The following is a description of a gene set: studied in species Homo sapiens Human Gene Set: MIR4477B from publication Chen Y, Wang X (PMID 31504780) Genes predicted to be targets of miRBase v22 microRNA hsa-miR-4477b in miRDB v6.0 with MirTarget v4 prediction scores > 80 (high confidence targets)., and this is the list of marker genes: CHCHD7, NAA30, ATP11A, MICAL3, MGAT4A, NEXN, DCP1A, NANP, STEAP2, CCNJ, HIPK3, FLRT3, SPRED1, MORC1, PHF6, WTAP, ZNF124, DYNLRB1, STARD5, MOB1B, TBL1XR1, SPOPL (speckle type BTB/POZ protein like), TRIM2, RNASE11, NID1, DGKH, BMP2, THBS1, PABPC1, PWP1, ZER1, TIPRL, SCN1A, KCTD7, AMZ1, PLAU, PDCD10, SREK1, CLOCK, CEP112, HEXIM1, AKAP8, MAGI3, EPM2AIP1, MED13, MON2, C14orf39, CDC73, UTP25, TSPYL1, DAZL, TMEM218, SPIN1 (NCBI Gene Id 95616), FGD4, CETN1 (NCBI Gene Id 1068), NCOR1, CRYL1, LSMEM2, PSME4, FKBP15, TCEANC, KAT6A, N4BP1, SLC27A6, AKR1E2, ELL2, RRM2B, SPTSSA, MKLN1, TXNDC16, GCN1, CEBPD, MAB21L1, PNPLA1, ZFP42, ATP5IF1, ZMYM1, PAQR3, REEP1, HSPA9, NUFIP2, ZCCHC14, ZCRB1, CASC3, CD19, RYR3, DDX46, GBP3, VPS53, PIK3C2A, GTF2I, EIF4G2, ATG5, FBXO25, BCL11B, ABL2, CHD6, TRAPPC3L, RAPGEF6 (Rap guanine nucleotide exchange factor 6), ERO1A, ATOSA, HDAC9 (NCBI Gene Id 9734), MEAF6, TTC22, PDE3B, MDGA2, ZBTB7A, CPPED1, GPSM2, GEMIN8, SRPK2, TBX3, SOCS4 (NCBI Gene Id 122809), CMC1, IPCEF1, COL5A2, DAAM1, HES5, CPEB1, ITPR3 (inositol 1,4,5-trisphosphate receptor type 3), KLHL14 (kelch like family member 14), SPON1, ARPP19, CETN3, GPT2, ZNF608, ENOSF1, MPZ, RAB30, MS4A12, GATAD2A, SERF2, INO80D, MRPL17, DZIP1, CCT8 (NCBI Gene Id 9888), MAP4K4 (NCBI Gene Id 9448), MAPKAPK2, VMA21, GET1, ANKRD13A, SPATA6L, VPS13C, RIF1, HECTD1, ARHGAP6, DHX40, SLITRK4, SNX6, SOD2 (NCBI Gene Id 79099), EPHA3, ACVR2A, ENDOV, GREM1, BMP6, LRRC19, SOX9, PHACTR2, RAI14, SMAP2, SULT6B1, CFL2, BMPR2 (bone morphogenetic protein receptor type 2), CCL4L2, HOOK1, PTGFR, FBXO22, SRSF2, CXCL6, PPP1CB, BRK1, ING3, TPD52L2, TGFBR3, SLC50A1, PTAR1, CPE, TMEM38B, DLG1, ADGRL3, CKMT2, MBOAT2, DENND2C (DENN domain containing 2C), TFDP1, USP10, PANK3, YAP1, HIVEP1, RCOR3, PRRG1, SLC1A4, ARHGEF3 (Rho guanine nucleotide exchange factor 3), GOLIM4, CIMAP3, RNF216, SPRTN, PON2, GNPNAT1, TMEM108, PEG3, RAB40B, SLC39A14, ELFN2, SORCS3, RMI1, ESRP2, FABP2, TRPM1, B3GALNT2, EPHA7, LMBR1, MINDY2, ADAM23, RPRM, AAK1, RPS6KA3, GPR22, ZDHHC9, TDRD6, DCUN1D5, PPCS, TEAD1, ARK2N, SGTB, RIOX1, UBE2A (ubiquitin conjugating enzyme E2 A), TTC21B, AEN, AAGAB, RELN, PCSK6, RNASE4, ZBTB10, ZNF333, ARHGAP18, FKBP5, OSBPL6, SLC46A3, TBCCD1 (TBCC domain containing 1), AIDA, EIF5A2, YOD1, RAB2A, DNM3, CDON, CPD, RHOBTB1, LUM (lumican), PTGDR, IFITM10, TEX12, UBR3, PSEN2, MAP3K2, EYA4, ZNF800, UNC50, GPR37, GALNT3, UTP14C, TCF4 (transcription factor 4), TIMMDC1, ZMYND19, SRSF8, SEC22B